The following is a description of a gene set: studied in species Mus musculus from publication Chen Y, Wang X (PMID 31504780) Mouse Gene Set: MIR_383_3P Genes predicted to be targets of miRBase v22 microRNA mmu_miR_383_3p in miRDB v6.0 with MirTarget v4 prediction scores > 80 (high confidence targets)., and this is the list of marker genes: Ppp2r3a, Vgf, Zic4, Arvcf, Trem6l, Fpr3, Ipo5, Zbtb10, Irf2, Gata3, Txnl4a, Srgap2, Rnf7, Ptbp2, Arhgap32, Slc5a1, Dnajc6, Homer1, Syn2, G3bp2, Lman2l, Zfp346, Ercc4, Dars2, Gzf1, Sprr1a, Nedd1, Ints6, Limk2, Ube2n, Sv2c, Tbc1d10b, Septin10, Patz1, Trp53inp1, Lias, Neurl3, Fzd4, Rbm12, Hoga1, Myh9, Etfbkmt, Smad5, Cyp2c54, Ube2o, Dtd1, Kdm2a (lysine (K)-specific demethylase 2A), Ubp1, Celf2, Zfp30, Crkl, Arl14ep, Zeb2 (zinc finger E-box binding homeobox 2), Wasf2, Ugt2b34, Dipk1a, Gab1, Nbea (neurobeachin), Maf, Prr14l, Arl6ip1, Unc5d, Glce, Akirin1, Ttc38, Stc1, Nqo2, Map3k2, Cds2, Pnpo, Ccdc149 (coiled-coil domain containing 149), D5Ertd579e, Hdx, Rab39b, Egr1 (NCBI Gene Id 13653), Zfp385b, Fbln2, Rgs8, Antxr1, Fbxw7, Fbxw22, Gimap6, Cnga3, Ppif, Brk1, Nipal4, Esr2, Shroom2, Pes1, Atxn1, Usp10, Hectd4, Ncald, Agtpbp1, Apaf1, Mlxip, Cav1, Myt1, Ino80d, Stx8, Maip1 (NCBI Gene Id 98197), Hat1, Tbl1x (transducin (beta)-like 1 X-linked), Csnk1d, Cep68, Shisal1, Necap1, Galnt1, Gmeb2, Kras, Nras (neuroblastoma ras oncogene), Scn2a, Edrf1, Wdr7, Chn2, Ywhag, Kif3a, Mideas, Myt1l, Plcl1, Tmem170b, Nlk, Tcf7l2, Tbx20, Ammecr1l, Pcdhga12, Zfp512b, Gch1, Brd2, Nxpe4, Dnajc5b, Dock3, Ndrg4, Kmt5b, Map1b, Dgcr2, Hnf4g, Pcyt1a (NCBI Gene Id 13026), Smad1, Slc38a8, Marchf6, Ago2, Tnfrsf23, Spata2, Eef1b2, Atg2a, Tardbp, Senp1, Avpr1a, Sh3glb1, Tnrc6b, Arl4c, Prl2a1, Osbpl11, Plcl2, S2bpcox16, Kdm5a, Hdac9, Pan3, Celf1, Dad1, Gbp3, Fndc3a, Fam43a, Ss18l1, Slitrk6, Snupn, Dzip1l, Rabl3, Dda1, Zfp36, Klhdc3, Mxd1, Scamp3, Arih1, Tmprss13, Ctr9, Ggt5, Dpyd, Gna14, Tdrkh, Fignl2, Bdnf, Asb7, Clec4e, Dnmt3a, Slc47a1, Runx1, Fbxw28, Sec14l3, Glcci1, Pate2, Cbx5, Peak1, Cnr1, Prdm1, Hmgn1, Cln8, Ap1g1, Sp6, Cep41, Zc3h18, Khdc1b, Cemip2, Egfr, Trmt12, Tfcp2l1, Cspp1, Spata13, Ids, Copz1, C2cd2, Adamtsl3, Sptbn1, Trim37, Mpp2, Exoc8, Zfp930, Srp54b, Ammecr1, Tmem161a, Relch, Kcns2, Gse1, Cavin1, Txn2, Tmem178b, Zbtb33, Arih2, Zfp644, Atg10, Pdpk1, Htr2c, Nub1, Amotl2, F8, Cyp2c50, Atad2b, Pip5kl1, Czib, Rab14, Zfp866, Fuca2, Zfp672, Fem1b, Mier3, Msn, Palld, Dcun1d4, Pdha1, Gcnt1, Mprip, Rdh13, Dmxl2, Rps24, Zdhhc8, Chd7, Itga7, Pcdh15, Prtg, Kcnf1, Dtx4, Ttyh3 (NCBI Gene Id 78339), Zmynd19, Gprin1, Wasl, Dyrk1a, Atp5mc3 (NCBI Gene Id 277484), Cox16, Rbsn, Ptpn3, Ank2, Afap1, Mapkbp1, Vapb